The following is a description of a gene set: Human Gene Set: GSE11961_MARGINAL_ZONE_BCELL_VS_MEMORY_BCELL_DAY7_UP To obtain insight into the genetic basis of the increase of functional activity of memory B cells over time, we compared the gene expression profiles of day 7 and day 40 NP-specific/IgG1 memory B cells, GC B cells and plasma cells in immunized WT mice and naïve B cells, before and after activation in vitro. Genes up-regulated in marginal zone B cells versus day 7 memory B cells. studied in species Homo sapiens from publication Kaji T, Ishige A, Hikida M, Taka J, Hijikata A, Kubo M, Nagashima T, Takahashi Y, Kurosaki T, Okada M, Ohara O, Rajewsky K, Takemori T (PMID 23027924), and this is the list of marker genes: UBAP1, ERGIC3, USP24, MAX, TAF8, ROCK1 (NCBI Gene Id 6093), CAP1, DYRK1A, ZIM2, KIT, NNMT, CEP44, CLEC14A, GABRG1, TCF21, LAX1, SMURF1, CADPS, XRN2, ATG9B, CFAP206, LRRC14 (leucine rich repeat containing 14), RPTOR, ATF6, CYP4F12, PCTP, PARD6B, LRPPRC, MSTO1, NR0B1, AFG1L, C11orf65, CXCR4, PHLPP1, HECTD1, MYO5B, CMTR1, MIP, CALHM2, ATG4D, SLC25A22 (NCBI Gene Id 79751), AK1, ATP7B, EIF2AK2, PI4KB, KAT7, HCN2, PRDM16, TRAPPC12, SCAMP2, IFIH1, FGFR1OP2, RSAD2, CTSE, HSPB7, USP18, AP1B1 (adaptor related protein complex 1 subunit beta 1), ITGA1, SAMD8, PTBP2, TIMMDC1, SCML4, FIS1, HOXD4, AMBRA1, ARFGAP3, XKRX, EZR, RGS13, UGGT1, LMF1, ERC1, NFAM1, BPIFC, MAP9, CEP43, WDR11, FITM1, TTC7A, MAGED1, EAF2, EHMT2, PARVB, CHMP1A, XRCC6, ZNF524, NRL, YWHAE, MBOAT1, GALNT12, VRK1, ATG2B, TSPOAP1, C16orf78, PTPRA, TAF3, USP4, ANAPC4, CCDC141 (NCBI Gene Id 375296), ZNF653, CFAP53 (NCBI Gene Id 220136), BAIAP2, PDIA5 (NCBI Gene Id 10954), TOR3A, SRSF10, FCHSD1, TMEM86A, SOX2-OT, NDUFS2, UQCRC1, HERC6, PUF60, ARAP1, TSSK2, GALNTL5, RCAN2, OPHN1, ZIC2, SPATA4, GALNT2, ARFGEF1, IFIT2, GIPR, CRYAB, NOG, SERPINB8, MS4A8, NEUROD1, IRF7, CDC25B, NBAS, SCAF8, CALB1, CTR9, DNAH17, RIPK4, MPHOSPH6, IFI27L2, AGPAT3, PSMA3, XAF1, OCEL1, BCL7B, CDK5RAP1, TXNL4A, INPP5A, TRIP10, ZNF664, SLFN5, TPI1, ZNF451, TRIB1, NABP1, CCDC125, PFKL, ABI1, PTPN23 (protein tyrosine phosphatase non-receptor type 23), DCUN1D5, RTN4, NDRG2, HERC3, FLNA, CD28, ZP3, NUDT15, C16orf86, AGK, TDP1 (NCBI Gene Id 55775), PRSS35, TRIM24, HSPB3, COQ2, CMPK2, ATP13A3, TGM4, EMCN, LYSMD1, IFIT1B (interferon induced protein with tetratricopeptide repeats 1B), RGS16, MINPP1, VTI1A, GNA15, HDAC10 (histone deacetylase 10), CLTRN, PDIA3, FBXL17, SYNDIG1L, ORAI3, PI16, TNRC6B, F5, VIM, SERTAD1, PFN1, SLFN13, HADHA, UNC119B, SPACA9, RNF220, ALDH3A2